The following is a description of a gene set: from publication Cui A, Huang T, Li S, Ma A, Pérez JL, Sander C, Keskin DB, Wu CJ, Fraenkel E, Hacohen N (PMID 38057668) Cytokines mediate cell-cell communication in the immune system and represent important therapeutic targets. A myriad of studies have highlighted their central role in immune function, yet we lack a global view of the cellular responses of each immune cell type to each cytokine. To address this gap, the authors created the Immune Dictionary, a compendium of single-cell transcriptomic profiles of more than 17 immune cell types in response to each of 86 cytokines (>1,400 cytokine-cell type combinations) in mouse lymph nodes in vivo. A cytokine-centric view of the dictionary revealed that most cytokines induce highly cell-type-specific responses. For example, the inflammatory cytokine interleukin-1β induces distinct gene programmes in almost every cell type. A cell-type-centric view of the dictionary identified more than 66 cytokine-driven cellular polarization states across immune cell types, including previously uncharacterized states such as an interleukin-18-induced polyfunctional natural killer cell state. Genes positively differentially expressed in cell type: Macrophage upon treatment with cytokine: TNF-α in mouse lymph nodes in vivo. Mouse Gene Set: CUI_MACROPHAGE_TNFA_RESPONSE_UP studied in species Mus musculus, and this is the list of marker genes: Ddx56, Tnfaip2, Myl12a (NCBI Gene Id 98073), Prkcd (protein kinase C, delta), Gtpbp4, Morf4l2, Actg1, Bcl2a1d, Cstb, Gbp5, Dcun1d5, Il1b, Tnfaip3, Ccl12, Eif6, Eif1, Sod2, Serpinb9 (NCBI Gene Id 20723), Etf1, Rnf19b, Hck, Eif5a, Malt1, N4bp1, Snx12, Gsap, Rbm3, Nfkb2, Tor1aip2, Basp1, Tuba1c, Maff, Mt2, Cd14, Ifrd1, Lilrb4b, Sdc4, Tma16, Efhd2 (EF hand domain containing 2), Ccl6, Dnajc21, Nlrp3, Marcks, Fkbp5, Mapkapk2, Rap1b, Ranbp1, Dusp2, Plek, Actr3, Pfn1, Eif4g2, Car13, Gda, Ptpn1, Nfkbie, Cxcl16, Ibtk, Fscn1, Tpm4, Mllt6, Clic4, Gpr137b, Nudt17, Txnrd1, Cdkn1a, Cfl1, Mrps7, Btg1, Il1a, Cxcl10, Filip1l, Mrps6, Cxcl13, Stk40, Atp6v1b2, Apip, Msr1, Procr, Psmd11, Bcl2a1a (B cell leukemia/lymphoma 2 related protein A1a), Uck2 (NCBI Gene Id 98564), Arl5c, Gch1, Srsf3, Ube2s, Eif4a1, H3f3a (H3.3 histone A), Snrpd1 (small nuclear ribonucleoprotein D1), Gadd45b, Tnip1, Csrp1, Psme3, Cdkn2b, Vasp, Chmp4b (NCBI Gene Id 96954), Arpc2, Socs3, Fnbp1l, Gosr2, Rab20, AA467197, Glipr2, Junb, Jdp2, Serpina3g, Tlr1, Ifitm2, Eef1e1, Riok3 (NCBI Gene Id 66878), Sumo2, Ncl, Sav1, Birc2, Batf, Med10, Ifi204, Tubb6, Smad2, Tmem123, Wfdc17, Clec4e, Steap4, Zfp593, Ran, Nfkbia, Ap3s1, Fth1, Psme2, Nus1, Bcl2a1b, Ubd, Psma6, C5ar1 (complement component 5a receptor 1), Srgn, Mtpn, Ccl9, Ehd1 (EH-domain containing 1), Plekha3, Ccl5, Clec4n, Gk, Utp11, Msantd4, Palld (NCBI Gene Id 72333), Cd55, Lcp2, Mt1, Cd200, Slfn2 (schlafen 2), Saa3, Etv6, Marcksl1, Foxp4, H3f3b, Relb, Il1rn, Myadm (NCBI Gene Id 50918)